Given this list of marker genes SLC2A2, SYNCRIP, USP3, AHCTF1, ONECUT2, SLC25A21, TMEM65, KCNH7, ZNF275, ZNRF2, GPD2, USP15, CLTC, RAG1, BMP2, PPP2R5E (protein phosphatase 2 regulatory subunit B'epsilon), GNG12, FOXD4L3, RBM46, ZBTB18, SFR1, RIMS2, OSM, FOXD4, DNAJB6, RPL36A-HNRNPH2, HORMAD1 (HORMA domain containing 1), TPGS2, NRARP, UBR3, ATP6V1A, CERKL, DCAF8L1, MND1, KCMF1, HYCC2, GTPBP8, LRP12, SLC7A11, BRIP1, NFAT5, TMEM237, PPP1CC, NR3C1, FGF12, CRTC2, TSPYL1, SLC10A2, DDB2, FAM135A, AKR1C2, PHACTR2 (NCBI Gene Id 9749), ZFP36L2, ZFYVE16, FOXG1, KLHL15, KHDRBS3, TMED7, HAPLN1, ZNF280D, ATP6V0D2, HNRNPH2, MECOM, PACC1, FBXO45, PIK3CA, ZNF493, GPRASP2, SPPL2A, GFAP, MON2, HEBP2, ADGRG2, PDS5A, PAK1IP1, MRFAP1, HIF1A, B4GALT6, SPRED1, CTNND2, ACVR1C, PIK3C2A, IBTK, DACH1, NUP153, GNPDA2, SPTBN1, PDHX, CERS3, TDP1, EDNRA, MYEF2, ACBD3, FBXO21, AMMECR1, UBN2, ZNF131, SBF2, NPR3, CDKN1B, AP1S3, ANTXR1, GRIK2, BNC2, BDP1, ANKLE2, PWWP2A, PRRG4, TMEM243, TMEM144, PLPPR5, THAP12, PTCH1, STRN (NCBI Gene Id 6801), PPP1R3D, HNRNPF, SUV39H2, LCTL, ADD3, DLK1, FAM120A, EP300, MLF1, SRSF2, NSUN6, FAT1, C5orf24, FBXL4, RNF11, CDK19, ADSS2, ABRA, SV2A, PPP2R2C, RBM41, MEGF10, A1CF, ZMYND19, PYGO1, SLITRK4, LIFR, SMARCAD1 (NCBI Gene Id 7303), SERINC5, SLC35E2A, SOX2, SLC4A4, CDH19, INSIG2, CHIC1, PPHLN1, ARF6, GYG2, BZW1, ALDOB, SLC35E2B, ZNF565, APBB2, CNOT6L, MAK, DNA2, BPNT2, CHL1, CAND1, TGFB2, UBXN7, TNPO1, RHEB, IMMP2L, RASSF10, ARHGAP11A, AP1AR, PEX13, SLC9A2, NUDT12, MAP3K2, TTLL7, SMAD4, DZIP3, VWC2, LATS2, VCF2 (VCP nuclear cofactor family member 2), TCP1, PPP1R12A, TGFBRAP1, ZMYM5, PDZD8, BTN2A2, PFDN1, NF1, FGFR2, ADH7 (alcohol dehydrogenase 7 (class IV), mu or sigma polypeptide), RAB27A, LRCH2, RBL2, ZHX3, PERP (NCBI Gene Id 64065), ATP2C1, TADA2B, CHD6, CATSPERB, KCTD8, CEP135, DDIT4L, NSMCE2, UBE3A, PNPLA8, LTBP1, STC1, ZNF302, B3GNT5, CTSS, CYCS (cytochrome c, somatic), ALKBH8, BHLHE40, CACNB4, SLC16A7 (solute carrier family 16 member 7), COX11, TNRC6B, CTHRC1, AHR, MIER3, RNF6, GCK, LYSMD3, NIFK, ARHGAP24, VMP1 (vacuole membrane protein 1), ATP6V1B1, TNFSF13B, NPY2R, UBE2D2, HOXC8, KANSL2, TBL1XR1, SLC11A2, NETO2, BTBD3, HACE1 (NCBI Gene Id 57531), DMXL1, RHOU, RNF145, GADD45A, UBE2B, B3GNT2, FMR1, SFPQ, KCNN4, WLS, CBLL1, TGFBR1, ARHGEF10, ZNF415, ZNF236, RBMX, FPGT, SRR, ANKRD62, DYRK4, WDR7, FXR1, TMX4, TUSC3, ARFGEF2, SNX16, GLIPR1L1, PACRGL, SNTG1, XAF1 (XIAP associated factor 1), USP38, FZD4, COL14A1, LRR1, MBNL3, PRDM16, DNAJC3, VMA21, CMKLR2, LAMA2, PTGR2, NETO1, ZNF667, LCLAT1, C7orf57, METTL15, TOR1AIP2, GARRE1, POU3F2, LZTFL1, FHIP1A, UTP6, DIP2C, DOCK4, CYB5R4, EDN1, LPCAT2, ZNF793, NCOA2, FBXL3, ABCD2, ERBB4, RECK, SH3GLB1, ADAMTS9, NDUFA10, FAM117B, SCAMP1, COQ2, ITPRID2, CENPJ, PPP5C, OSBPL6, ZNF704, ARAF, CUL5, HDHD2, ATRN, CEMIP2, PAIP2B, CHORDC1, ZEB1, SYNPR, MBNL1, CTNNA3, CRACD, DUSP16, KHDRBS2, CNEP1R1, SLC30A8, HEY2, KIF3A, OTX2, NEFL, TGFA, TNRC6A, EMCN, INO80D, ZNF780B, TMEM33, DPY19L4, FGA, EMC4, EDNRB, ECHDC1, HSPA1B, RORA, OMA1, ASZ1 (NCBI Gene Id 65976), CLVS2, ADAM23, SNX25, RB1CC1, HNRNPDL (heterogeneous nuclear ribonucleoprotein D like), RIMOC1 (NCBI Gene Id 285636), JMY, CDIN1, GPR180, CFLAR, ABHD18, UBE2W, ZCCHC4, HTR2C, ATP6V1B2, TNFSF15, RAP1B, TMEM209, PHIP, MGST1, MSANTD3-TMEFF1, DGKH, ARL1, MDFIC, BRAF, COL11A1, LIN9, CFAP65, MTERF3, SEC62, ERCC8, CD274, HACD3 (NCBI Gene Id 95112), BBS7, TMEFF1, RPS6KA6, PRDM11 (NCBI Gene Id 56981), IL1RAP, SEC24D, SON, AVPR1A, SRSF12, UBQLN1, PBX2, NAB1, RPAP3, ATF7IP, RAB21, POU2F2, CREBZF, STEAP2, RALGPS1, PCF11, CDK8, GBE1, ZFP36L1 (ZFP36 ring finger protein like 1), KCTD18, ZFPM2, ATXN7, DAZAP1, RCHY1, MYT1, GNAI1, ZNF529, CD200R1, NOX4, ADH4, EPHA7, SESN1, MACROH2A1, HTATSF1, NAA50, CFHR4, FOXD4L6, SMIM8 (NCBI Gene Id 63914), NXPE3, PRPF38B, EIF2AK1, SIX4, COX7A2L, SESN3, OSBPL8, VPS37A, KCNQ4, ADGRL3, TFRC, FOXN2, TEAD1, RTKN2, WASHC3, TRIM2, UQCRB, PWWP3B, LCOR, SPRY1, GPHN, CAB39, LRRTM2, SLC38A4 (solute carrier family 38 member 4), GLI3, FOXD4L1, MKRN3, ZIC3, CPT1A, MAPK9, PTP4A1, STMN2, PPM1A, WNT2, DPY19L1, ANK2, CRKL, ZNF483, SH3BGRL, SPCS2, CDH6, C5orf15, PRR23C, CREBBP, TM4SF4, RNF138, CARNMT1, LARP4, CEP126, ENSG00000286190, MSRB3, TTC14, TRIM13, ZNF678, ASF1A, EHF, PBX3 (PBX homeobox 3), RBMXL1, FGF13, DERL3, MKX, FRYL, BRWD1, TBL1X, ZDHHC21, ZNF195, AFDN, IFT57, CADM2, TMEM245, DCP2 (NCBI Gene Id 167227), NAA16, GLCE, STAM, OR2C3, HNRNPH1, DMC1, TP63, MLLT1, SETD1A, MARS2, CYFIP2, HNRNPR, ZC3H12C, OLFM3, PMCH, PHKB, PSIP1, RIN2, CCDC186, XPNPEP3, RPRD1A, DNAJC21, SATB1, CEP170, LCORL, DDHD1 (NCBI Gene Id 80821), AMOTL1, GTDC1, TAB3, THBS1 (thrombospondin 1), IDI1, PDE8A, KDM4D (NCBI Gene Id 55693), PKDCC, ELK4, CGGBP1, CEP97, ELOVL6, LRP1B, REST, IRS2, ELF1, MBTD1, MAP1LC3B, INTU, SLC1A3, NYAP2, PLK4, FAHD1, BCAP29, ELMOD2, TCEANC2, GPCPD1, SOCS5, MTMR6, LAMA3, DNAH14, TGOLN2, CCNY, TMPRSS7, EIF4A2, ATP6V0A2, ETV1, NDUFB4, CDK17, TMEM168, ST6GALNAC3, AK3, ZEB2, TRDN, CLDN12, LMBRD1, BMP2K, PRTG, EIF5A2, ZCCHC24, FLT1, SIPA1L2, STK17B, MINDY3, MEIS2, HNF4G, TAB2, IRF5 (NCBI Gene Id 84729), RASSF3, FBXO33, here is a description of the gene set: from publication Chen Y, Wang X (PMID 31504780) species: Homo sapiens Human Gene Set: MIR302C_5P Genes predicted to be targets of miRBase v22 microRNA hsa-miR-302c-5p in miRDB v6.0 with MirTarget v4 prediction scores > 80 (high confidence targets).